The following is a description of a gene set: studied in species Mus musculus Mouse Gene Set: GOMF_ORGANOPHOSPHATE_PHOSPHATE_ANTIPORTER_ACTIVITY Enables the transfer of a solute or solutes from one side of a membrane to the other according to the reaction: organophosphate(out) + phosphate(in) = organophosphate(in) + phosphate(out)., and this is the list of marker genes: Slc25a23, Slc37a4, Slc37a2, Slc37a1, Slc25a25, Slc25a24